Given this list of marker genes DHCR7, SCP2, ACOT9, NPC1, ACOT6, CYP7A1, CYP27A1, THEM5, ACOT12, SLC27A2, DBP, NPC2, ACOT2, ACOT1, BAAT, ACOT4, ACOT11, EBP, HSD11B1, AMACR, ACOX2, ACOT8, ACOT13, EPHX2, HSD11B2, ACOT7, SLC27A5, here is a description of the gene set: 7-oxo-C and 7-beta-HC pathways Human Gene Set: WP_7OXOC_AND_7BETAHC_PATHWAYS studied in species Homo sapiens